The following is a description of a gene set: In this study, an extensive analysis was conducted to define meta-programs (MPs) capturing intra-tumor heterogeneity across a spectrum of tumor types. The approach utilized non-negative matrix factorization (NMF) to analyze each cell type separately within individual tumor samples. This involved the analysis of malignant cells, macrophages, fibroblasts, endothelial cells, epithelial cells, T-cells, and B-cells. NMF was executed with varying parameter values (K=4, 5, 6, 7, 8, 9), thereby generating 39 programs for each cell type per sample. Each NMF program was summarized by the top genes based on NMF coefficients.\nRobust MPs were then delineated for each cell type using a set of stringent criteria, including recurrence within the same tumor, similarity to programs in other tumors, and non-redundancy within a tumor. Subsequently, these robust NMF programs were clustered (per cell type) based on Jaccard similarity, leading to the identification of MPs associated with each cell type.\nTo enhance the quality of the MPs, a refinement steps were undertaken, involving the removal of MPs suspected of reflecting low-quality data (with an overrepresentation of ribosomal proteins or mitochondrial-encoded genes), single-study inclusion, or similarity to miss-annotated cell types. Human Gene Set: GAVISH_3CA_METAPROGRAM_ENDOTHELIAL_ENDO_1 from publication Gavish A, Tyler M, Greenwald AC, Hoefflin R, Simkin D, Tschernichovsky R, Galili Darnell N, Somech E, Barbolin C, Antman T, Kovarsky D, Barrett T, Gonzalez Castro LN, Halder D, Chanoch-Myers R, Laffy J, Mints M, Wider A, Tal R, Spitzer A, Hara T, Raitses-Gurevich M, Stossel C, Golan T, Tirosh A, Suvà ML, Puram SV, Tirosh I (PMID 37258682) Genes upregulated in subsets of cells of a given type within various tumors species: Homo sapiens, and this is the list of marker genes: LBH, TP53I11, PLPP3, CDH13, RGCC, MLEC, ITGA1, VWA1, NID1, HECW2, GJA1, EDNRB, PTP4A3, CXCR4, COL4A2, UNC5B, PDGFD, NOTCH4, NHERF2, ACE (angiotensin I converting enzyme), LAMA4, SPRY4, CA2, HSPG2, PODXL, MCAM, COL4A1, IGFBP3, FLT1, ADGRF5, ANGPTL2, TIMP3, FCN3, TM4SF18, IVNS1ABP, GRB10, ANGPT2, KDR, INSR, MMP2, PXDN, ESM1, STC1, MIR4435-2HG, TNFRSF4, COL15A1, PLVAP, MYO1B (NCBI Gene Id 92451), HTRA1, SPARC